The following is a description of a gene set: studied in species Mus musculus part of: APC/C:Cdc20 mediated degradation of mitotic proteins electronically inferred by orthology from the curated human pathway This event has been computationally inferred from an event that has been demonstrated in another species.<p>The inference is based on the homology mapping from PANTHER. Briefly, reactions for which all involved PhysicalEntities (in input, output and catalyst) have a mapped orthologue/paralogue (for complexes at least 75% of components must have a mapping) are inferred to the other species. Reactome Pathway: APC/C:Cdc20 mediated degradation of Cyclin B, and this is the list of marker genes: Ube2d1, Anapc15, Ube2s, Anapc2 (NCBI Gene Id 99152), Cdk1, Ube2e1, Ccnb1, Anapc7, Ubb (NCBI Gene Id 22187), Ube2c, Anapc10, Rps27a, Cdc26, Cdc23 (CDC23 cell division cycle 23)